Given this list of marker genes Dctd, Dctpp1 (dCTP pyrophosphatase 1), Nt5c1b, Gusb, Fbxo27, Hpse, Ogt, Slc2a6, Lyve1, Fgf2, Ep300, Bcl2l13, Nt5c1a, Mtor, Neu4 (sialidase 4), Aldh1a7, Flcn, Hif1a, Adal, Gba1, Psen1, Stab2, Slc4a4, Tymp, Enpp1, Abhd10, Prkag2, Glb1, Col6a1, Tpi1 (NCBI Gene Id 21991), Eno4, Nt5m, Edem3, Ahcy, Neu2, Prkag3, Fuca1, Ifng, Entpd1, Aldob, Prkcd, Galm, Nudt18, Sik2, Pfkm, Pfkfb2, Gpd1, Hk2, Eno1b, Btk, Renbp, Kat2b, Aldh1a1, Pde8a, Slc29a1, Nudt3, Nt5c3, Sirt6, Pglyrp2, Arnt, Khk, Esrrb, Aoah, Fuca2, Cdadc1, Hkdc1, Nudt1, Trex1, Ogdh, Hyal1, Entpd7, Pycr3, Fbxo2, Idua, Hk1, Ddit4, Pde9a (NCBI Gene Id 18585), Fkrp, Prkag1, Mlst8 (MTOR associated protein, LST8 homolog (S. cerevisiae)), Pnliprp2, Cbfa2t3, Pglyrp1, Chil3, Pde4a, Mtch2, Mlxipl, Entpd4b, Naglu, Man1a, Hk3, Nudt15, Chia1, Nt5e, Cda, P2rx7, Mfsd8, Pde7b, Urad, Dhtkd1, Src, Lipa, Hmmr, Pnp, Ins2, Jmjd8, Cd44, Nagk, Nudt9, Entpd5, Npl, Hyal6, Hexa, Hdac4, Eif6, Pglyrp3, Mgat1, Htr2a, Adamts12, Pfkl (NCBI Gene Id 18641), Gapdhrt2, Gpi1, Gns, Ctbs, Galc, Aldoa, Insr, Bpgm, Prkaa1, Galt (galactose-1-phosphate uridyl transferase), Gck, Tkfc, Nudt11, Pgk2, Nupr1, Chil5, Adpgk, Eno2, Lct, Fbxo44, Hyal3, Gpc1, Hexb, Gapdhs, Urah, Ncor1, Tgfb1, Pde10a, Lyg2, Ovgp1, Dpys, Cemip (cell migration inducing protein, hyaluronan binding), Gapdhrt, Prxl2c, Chi3l1, Amdhd2, Pfkfb1, Chil6, Nudt16, Dpyd, Arsb, Upb1, Gpd1l, Fbp1 (NCBI Gene Id 14122), Manba, Foxk2, Pde1a, Edem2, Pde5a, Dut, Gale, Aldoart1, Pde8b, Aicda (NCBI Gene Id 11628), Slc4a1, Hyal5, Ins1, Naga, Nt5c2, Nudt4, Galk1, Uchl1, Mlx, Hyal4, Hprt1, Ppp2ca, Galns, Ier3, Pde4d, Neu3, Dnph1, Zbtb7a, Lyg1, Eno3, Ngly1 (NCBI Gene Id 80535), Myc, Pkm, Gda, Cst3, Fbxo17, Prkaa2, Zbtb20, Aldoart2 (NCBI Gene Id 79459), App, Xdh, Pglyrp4, Itpa, Pnp2, Ppargc1a, Pgam1, Ctsl, Dera, Gnpda2, Ada, Upp1, Gmpr2 (NCBI Gene Id 70653), Git1, Hint1, Aldoc, Ids, Mmp12, Cela1, Ppara, Gla, Trim63, Enpp4, Tigar, Arl2, Spam1, Mpi, Pde2a, Fbxo6, Hgsnat, Entpd4, Foxk1, Pgk1, Pde7a, Psap, Pgm1, Myog, Ampd3, Nccrp1, Eno1, Neu1, Cemip2, Gnpda1, Chil4, Igf1, Prkaca, Hyal2, Il3, Ucp2, Actn3, Samhd1, Man1b1, Pde4c, Gm2a, Rptor, Ahcyl, Slc9a1, Pgam2, Uox (urate oxidase), Nudt10, Pfkp, Gba2, Upp2, Edem1, Pklr, Sgsh, Chit1, Nt5c, Stat3, Stt3b, Gapdh, Pfkfb3, here is a description of the gene set: Mouse Gene Set: GOBP_CARBOHYDRATE_DERIVATIVE_CATABOLIC_PROCESS The chemical reactions and pathways resulting in the breakdown of carbohydrate derivative. studied in species Mus musculus